The following is a description of a gene set: species: Homo sapiens Human Gene Set: GCTTGAA_MIR498 Genes having at least one occurence of the motif GCTTGAA in their 3' untranslated region. The motif represents putative target (that is, seed match) of human mature miRNA hsa-miR-498 (v7.1 miRBase)., and this is the list of marker genes: RNF149, STXBP5, RUNX2, MEIS1, DICER1, SLITRK2, SRSF10, CCNT2, ABTB1, CMPK1, CAPZA2, KLF12, ATPAF1, SNRK, TSC22D3, DHX35 (NCBI Gene Id 60625), CRH, CELF1, NAP1L3, SOX11, ITSN1, SMC1A, ARRDC3, IRF2, MECP2, PKNOX2, HBP1, EML4, ATOSB, SREK1, BAHD1, MAPRE1, DERPC, CPNE8, UBE2J1, LSM12, SOCS3, FYTTD1, SIX4, ZEB2, NAA15, KCND2, SPRED1, ZFP36L1, PAM, RNF11, PTCH1, DCAKD, ZNF518A, MORF4L2, PACSIN2, SLF2, FANCA, ZIC4, BACH2, PHF6, ANKRD28, RBPMS, TSC22D2, RAB6A, YPEL2, PDE4B, PIP4P2, ARL4C, WT1, ATP2B1, TMED10, PURG, COL1A1, OLIG3, C1orf21, DCBLD2, WDR26, GRIA2, DUSP4, MAB21L1 (NCBI Gene Id 4081), PDIA6, RNF43, ITPRID2, GJA1, RAB22A, COA7, PSD3, RNF125, DTNA, ST8SIA2, C5, EXOC5, CHODL, CACNA2D3, HIPK1, NCOA1, FLRT2, PIK3R1, PPP3CA, BCORP1, TFRC, FERMT2, RBM24, KPNB1, CADM2, TMEM245, LRP1B, EPB41L4B, MOB1B, CCNE1, SS18L1, CBX4, CAMK2G, RAB11A, AGBL5, CTNS, HAPSTR1